Given this list of marker genes Mas1, Agtr2, G6pdx, Agt, Mrgprd, here is a description of the gene set: The process that increases the diameter of a blood vessel via the renin-angiotensin system. Mouse Gene Set: GOBP_ANGIOTENSIN_MEDIATED_VASODILATION_INVOLVED_IN_REGULATION_OF_SYSTEMIC_ARTERIAL_BLOOD_PRESSURE species: Mus musculus